The following is a description of a gene set: Formation of a prolongation or process extending from a cell, e.g. a flagellum or axon. Mouse Gene Set: GOBP_CELL_PROJECTION_ASSEMBLY studied in species Mus musculus, and this is the list of marker genes: Dcx, Alpk1, Ift80, Mtss2, Arl3, Wrap73, Mkks, Rabep2, Cdkl5, Ttll8, Cfap53, Arhgef4, Atg3, Nphp3, E2f4, Mak, Mir129-2, Dbn1, Ttyh1, Zmynd8, Wdr44, Lrrc23, Stau2 (staufen double-stranded RNA binding protein 2), Meig1, Inpp5k, Micall1, Ift74, Rpgrip1l, Bin3, Zmynd10, Dync2i2, Tekt2, Spef2, Rdx, Csnk1d, Fscn1, Rilp, Vav3, Ift52, Ttc21b, Cdkl1, Rapgef2, Alms1, Rab11a, Daam2, Ift172, Cby1, Cfap43, Vcl, Macir, Nck2, Ccdc103, Tekt4, Lama5, Cyld, Wasf2, Cdc42ep4, Cntrob, Ubxn10, Noto (NCBI Gene Id 384452), Onecut2, Spag6l, Misfa, Adamts16, Dnaaf4, Cep97, Ablim2, Nck1, Wwtr1, BC048507, Plk4, C2cd3, Odad1, Twf2 (NCBI Gene Id 23999), Carmil1, Dnah8, Abitram, Poc1a, Ift57, Spag6, Dnah1, Vdac3, Fuz, Ccdc113, Rilpl2, Elmod3, Plxnb3, Celsr2, Sclt1, Myo1a, Dnaaf3, Qrich2, Cyfip1, Tmem138, Dnah7c, Fnbp1l, Bbip1, Kif3b, Dnai3, Hnf4a, Cfap100, Tnik (TRAF2 and NCK interacting kinase), Stap1, Cplane2, Lrrc61, Sh3yl1, Cdc42ep1, Ift27, Ccdc38 (NCBI Gene Id 237465), Twf1, Ift43, Wnt1, Cenpj, Kif24, Whamm, Pcnt, Cep250, Mtor, Klhl41, Ccdc65, Armc12, Enkd1, Cep164, Ablim3, B9d1, Fmr1, Odf2, Spag17, Wdr19, Odad3, Kctd17, Ccl21d, Unc119b, Disc1, Frmd7, Ehd4, Cc2d2b, Spaca9, Iqcg, Myh10, Dynll1, Ccdc15, Bloc1s6, Pip5k1a, Rab5a, Dctn1, Ccdc159, Emp3, Mns1, Snx10, Gfy, Tpgs1, Exoc5, Cfap69, Prdx6, Rfx2, Rp1, Pierce2, Atxn10, Cep89, Atp6v1d, Ttll5 (tubulin tyrosine ligase-like family, member 5), Tmem107, Ift46, Rfx3, Stx2, Fam110c, Stil, Cobl, Tekt5 (tektin 5), Nek1, Cfap74, Clxn, Kit, Actn2, Cep128, Podxl, Wdpcp, Hoatz (NCBI Gene Id 73763), Zfp423, Ube2b, Rac2, Dnm3, Cc2d2a, Dzip1, Pdcl2, Lrguk, Rala, Fgd3, Dnah5, Txndc15, Ift25, Fmnl3, Rsph9, Dnali1, Ttll1, Rap2a, Dtnbp1, Anln, Erich3, Atp7a, Luzp1, Rsph4a, Kif27, Rac3, Cfap70, Atg5, Ptpn23, Rhoq, Limk2, Cfap47, Cep131, Arhgap35, Cplane1, Mapre1 (microtubule-associated protein, RP/EB family, member 1), Dusp23, Mir34c, Actr3, Syne1, Sdccag8, Src, Spag16, Rac1, Ccdc13, Abl2, Mir449c, Carmil2, Septin7, Ssx2ip, Intu, Armc2, Cep41, Palm, Akap4, Gmnc, Lima1, Cep350, Avil, Was, Arid1b, Scin, Epha2, Tchp, Apc, 4933427D14Rik, Ptpdc1, Def8, Srgap2, Traf3ip1, Icam1, Fam161a, Odf2l, Ppp1r16b, Ptpro, Nme5, Cspg4, Cdk10, Agrn, Rab17, Dnai1, Gorab, Tbc1d7, Gdi2, Rsph6a, P2rx7, Plek2, Mks1, Cfap97d1, Cluap1, Fgd1, Yif1b, Vstm5, Dnajb13, Cfap58, Pla2g3, Entr1, Tctn2, Gsk3b, Nudcd3, Cfap298, Emp1, Inpp5e, Dnaaf11, Dnaaf6, Ccdc57, Mir34b, Tmem80, Iqcb1, Cibar1, Golph3, Bbs2, Arl6, Lpar1, Dnmbp, Cfap73, Septin2 (NCBI Gene Id 98678), Prkcd, Cep290 (centrosomal protein 290), Dnaaf6rt, Pcm1, Lpar3, Ro60, Rabl2, Ehd1, Fsip2, Ccp110, Cep19, Abcc4 (NCBI Gene Id 239273), Rp1l1, Ccdc63, Cfap157, Odad2, Ttc39c, Eps8l3, Actr2, Shtn1, Pdgfb, Arhgef6, Sh2b1 (NCBI Gene Id 77601), Cdc14b, Dnhd1, Arl13a, Wdr90, Evi5l, Nckap1l, Akt1, Flna, Cfap410, Gk2, Dnaaf1, S1pr1, Bag4, Syne2, Gap43, Bbs5, Pls1, Asap1, Kcnf1, Ajuba, Ift122, Cdc42, Tbc1d31, Ift70b, Ezr, Cabcoco1, Dnaaf10, Fgfr1, Hrg, Celsr3, Rpgr (retinitis pigmentosa GTPase regulator), Cln3, Ccr7, Ift140, Stk36, Srf, Itga6, Ccdc146, Cd2ap, Ccdc96, Cfap91 (cilia and flagella associated protein 91), Cdc14a, Cfap54, Ttbk2, Dpysl3, Dock11, Tmem216, Tbc1d21, Nme8, Ppp1r35, Bbs9, Gsn, Arf4, S1pr2, Mir449a, Rab8a, Fbxw8, Klf5, Tmem17, Arhgef7, Hap1, Ehd3 (NCBI Gene Id 57440), Fsip1 (NCBI Gene Id 75478), Aif1l, Vangl2, Inppl1, Togaram1, Rock1, Ccdc66, Cdc42ep5, Mark4, Tmem231, Kif3a, Ak7, Capzb, Mien1, Abi3 (NCBI Gene Id 66610), Rapgef6, Tacstd2, Dnai4, Fam98a, Dnm2, Hyls1, Nherf1, Dnah2, Htt, Ulk4, Zmynd12, Fgd4, Ndel1, Emp2, Ccl21a, Kcnq1 (potassium voltage-gated channel, subfamily Q, member 1), Parvb, Notch1, Ripor2, Gm14137, Tsga10, Cfap206, B9d2, Dnai2, Hsp90aa1, Arhgap44, Ift88, Odad4, Kcnj10, Fgd2, Fbf1, Daw1, Tbc1d30, Dnaaf5, Yap1, Cep20, Spag1, Pkhd1, Wasf3, Pfn4, Bbs4, Clcn4, Cfap20, Drc1, Atmin, F2rl1, Vav2, Cdc42ep3, Tgfb3, 1700012B09Rik, Espn, Pierce1, Ntn1, Cfap119, Pxn (NCBI Gene Id 19303), Jhy, Ston1, Dnah7a, Dync2li1, Ccl21b, Prl2c2, Myo10, Rab29, Mapk15, Bbof1, Rhog, Fer, Nckap1, Cyfip2, Tenm2, Cep120, Tctn3, Dcdc2a, Hydin, Prkcq, Ccdc40, Brk1, Usp9x, Itgb1, Myo3b, Tctn1, Tapt1, Itgb4, Ccl19, Eps8, Rpgrip1, Cibar2, Mir449b, Wdr35, Rilpl1, Pdgfrb, Ccno, Stk26, Saxo1, Plekhm1, Cfap61, Lrrc46, Dnah7b, Spata6, Auts2, Poc1b, Arf6, Kank1, Cttn, Snap29, Nlgn1, Rap1gap, Ift22, Tekt3, Dmtn, Ttll3, Pmp22, Rab23, Ccdc28b, Pik3r1, Arhgap24, Pcdh15, Rab34, Ablim1, Clrn1, Cep83, Neurl1a, Arap1, Atp6v0d1, Mcidas (NCBI Gene Id 632552), Eps8l1, Ocrl, Pdgfa, Gpm6a, Tekt1, Ift81 (NCBI Gene Id 12589), Cdh13, Ttc12, Wdr11, Arpc2, Parvg, Aqp1, Onecut1, Armc9, Pqbp1, Ift20, Ift56, Spef1, Plce1, Spata13, Tmem67, Rhod, Sh3bp1, Vil1, Ppp1r9b, Tbc1d32, B3glct, Mylk, Plppr5, Pld1, Dzip1l, Parva, Tgfbr1, Cfap221, Abl1, Trim32, Evl, Ccl21f, Rsph1, Tenm1, Pfn2, Nup85, Dynlt2b, Cfap65, Prickle1, Galnt11, Dnaaf2, Ano6, Ccl5, Eps8l2 (EPS8-like 2), Bbs1, Ccdc42, Trappc14, Marchf7, Klc3, Ccdc39, Aif1, Iqcn, Pibf1, Bbs10, Coro1c, Bbs7, Dync2i1, Cilk1, Cfap44, Rfx4, Ccl21e, Cep162, Wasl, Slit2, Rab3ip, Iqub, Ccdc88a, Ttc8, Elmod1, Rab11fip3, Nrp1, Rcc2, Gas8, Usp17le, Atp8b1, Mphosph9, Ephb2, Abi2, Cdc42ep2, Arl13b, P2ry12, Cep135 (centrosomal protein 135), Capg, Cfl1, Myo3a, Cep70, Tesk1, Drc7, Fhdc1, Crocc, Foxj1, Cfap161, Nrxn1, Fam149b, Trpm2, Septin9, Hras, Fbxo24, Ahi1, Tmem237, Ehd2, Dnah17, Mstn, Cep126, Cav1, 2700049A03Rik, Ppp1r9a, Akirin1, Dync2h1, Cfap57, Hdac4, Pfn1 (profilin 1), Arhgef26, Dnal1 (NCBI Gene Id 74212), Ofd1